The following is a description of a gene set: Platelet calcium homeostasis Mouse Gene Set: REACTOME_PLATELET_CALCIUM_HOMEOSTASIS species: Mus musculus, and this is the list of marker genes: P2rx6, Calm3, Sri, P2rx7, Atp2a2, P2rx4, Trpc6, Calm1, Calm2, Trpc3, Trpc7, Itpr3, Itpr2, Atp2b4, P2rx2, Slc8a2, Slc8a1, Atp2b1 (NCBI Gene Id 67972, ATPase, Ca++ transporting, plasma membrane 1), Slc8a3, Atp2a1, P2rx5, Atp2a3, Atp2b2 (NCBI Gene Id 22426), Atp2b3, P2rx3, Itpr1, P2rx1